Given this list of marker genes PGAP4, KLC2, MNT, CDK14, NLGN3, PCM1, AGAP1, PURA, CLSTN1, MAGED1, CALM2 (calmodulin 2), WDR81, HGF, RTN3, ASIC2, KPNA1, DDX6, SANBR, HPSE2, LSM11, CTCF, TMEM14A, ANXA6, EWSR1, UVRAG, NONO, CAST, TOPORS, APP, NCS1, EPB41L3, MLLT11, VSNL1, ATP13A1, EIF4G2, TTC9C, IKZF2, PNMA6A, GSK3A, KCNS3, LRFN5, PRRC2C, SFXN5, RHBDD3, NHERF2, CPNE1, SRSF8, MBTPS2, DGKD, SRGAP2, ARHGAP5, PRDM13, NOVA1, TAOK2, HAUS6, PHEX, PDCL3, ADGRB2, TACC2 (transforming acidic coiled-coil containing protein 2), CLTC, MAP2K7, PNMA3, RIBC1, NOP56, OGA, KCNN2, TRIM9, GSPT1, FGFR1, CALM3, ASPHD1, EPHB1, USP8, GBF1, SMC1A, NNAT, SRSF9, CADM2, PLEKHA1, ZDHHC15, C11orf87, VAMP1, GDE1, IL1RAPL1, BMPR2, FAM13B, CDC42SE1, STX16, GAB2, MAP1B, KMT2E, HACD3, GANAB, PAQR9, FBXO11, AHI1, KIZ, CHD2, ADNP, CCP110, ELP2, EIF5A (NCBI Gene Id 1984), CSDE1, ASCL1, SEMA7A, PSAP, CAMK1D, ASCL2, ELOVL4, SLC39A6, SLC32A1, MIR22HG, TMEM88, NRXN1, SYNJ1, HS3ST3B1, MAT2A, HMGCLL1, FGF13, OLFML3, SARS1, SYT12, NRXN3, TMEM151A, KCNA1, OCIAD1, SOBP, here is a description of the gene set: Comprehensive identification of all functional elements encoded in the human genome is a fundamental need in biomedical research. Here, we present a comparative analysis of the human, mouse, rat and dog genomes to create a systematic catalogue of common regulatory motifs in promoters and 3' untranslated regions (3' UTRs). The promoter analysis yields 174 candidate motifs, including most previously known transcription-factor binding sites and 105 new motifs. The 3'-UTR analysis yields 106 motifs likely to be involved in post-transcriptional regulation. Nearly one-half are associated with microRNAs (miRNAs), leading to the discovery of many new miRNA genes and their likely target genes. Our results suggest that previous estimates of the number of human miRNA genes were low, and that miRNAs regulate at least 20% of human genes. The overall results provide a systematic view of gene regulation in the human, which will be refined as additional mammalian genomes become available. Human Gene Set: YGCANTGCR_UNKNOWN studied in species Homo sapiens Genes having at least one occurrence of the highly conserved motif M96 YGCANTGCR in the regions spanning 4 kb centered on their transcription starting sites. The motif does not match any known transcription factor binding site. from publication Xie X, Lu J, Kulbokas EJ, Golub TR, Mootha V, Lindblad-Toh K, Lander ES, Kellis M (PMID 15735639)